The following is a description of a gene set: species: Homo sapiens part of: Drug resistance in ERBB2 KD mutants Reactome Pathway: Resistance of ERBB2 KD mutants to lapatinib This pathway describes resistance of ERBB2 KD mutants to tyrosine kinase inhibitor lapatinib., and this is the list of marker genes: ERBB2, CDC37, HSP90AA1, ERBIN